Given this list of marker genes VPS52, EIPR1, VPS53, VPS50, VPS51, here is a description of the gene set: A quatrefoil tethering complex required for endocytic recycling. Human Gene Set: GOCC_EARP_COMPLEX studied in species Homo sapiens